Given this list of marker genes IL1RAPL1, C8orf34 (chromosome 8 open reading frame 34), RANBP9, IL25, NHLH2 (nescient helix-loop-helix 2), DRG1, DKK1, FGF7, GADD45A, DMD, NTRK2, CHMP2B, RPL27A, LONRF3, MRPL58, CRACR2B, MOAP1, ERG, CDKL5, COL9A1, EMC3, ATP6V1B2 (NCBI Gene Id 526), RREB1, HOXC4, CRYAB, ASTN1 (astrotactin 1), CNKSR2, CSMD3, SMOX, PCNT, PIK3R3, SREBF2, PHYHIP, GTF2IRD1, TMEM109, PTCHD4, FAM53C, MIR9-1HG, SPEM1, PAX9, GAB2, HDX, ASIC2, GNB3, TSPAN33, WFIKKN2, CSPG5, CNTRL, NCDN, CACNB2, GPATCH2L, SSX2IP, TNFSF4, GPX1, PIK3R1, PHOX2B, ERRFI1, GRIA1, CCDC3, SOX4, CABP1, TP63, NXPH4, HSPB2 (heat shock protein family B (small) member 2), SKIDA1, NRP2, SOX10, SOCS1, SP8, SEPTIN9, ADGRF2P, GABARAP, ENSG00000291228, RHOBTB2, here is a description of the gene set: Comprehensive identification of all functional elements encoded in the human genome is a fundamental need in biomedical research. Here, we present a comparative analysis of the human, mouse, rat and dog genomes to create a systematic catalogue of common regulatory motifs in promoters and 3' untranslated regions (3' UTRs). The promoter analysis yields 174 candidate motifs, including most previously known transcription-factor binding sites and 105 new motifs. The 3'-UTR analysis yields 106 motifs likely to be involved in post-transcriptional regulation. Nearly one-half are associated with microRNAs (miRNAs), leading to the discovery of many new miRNA genes and their likely target genes. Our results suggest that previous estimates of the number of human miRNA genes were low, and that miRNAs regulate at least 20% of human genes. The overall results provide a systematic view of gene regulation in the human, which will be refined as additional mammalian genomes become available. from publication Xie X, Lu J, Kulbokas EJ, Golub TR, Mootha V, Lindblad-Toh K, Lander ES, Kellis M (PMID 15735639) Genes having at least one occurrence of the highly conserved motif M153 CTGRYYYNATT in the regions spanning 4 kb centered on their transcription starting sites. The motif does not match any known transcription factor binding site. Human Gene Set: CTGRYYYNATT_UNKNOWN species: Homo sapiens